The following is a description of a gene set: species: Mus musculus Mouse Gene Set: GOBP_PEPTIDYL_SERINE_AUTOPHOSPHORYLATION The phosphorylation by a protein of one or more of its own serine amino acid residues, or a serine residue on an identical protein., and this is the list of marker genes: Pikfyve (NCBI Gene Id 71407), Prkca, Mark3, Atm, Ripk1, Map2k2, Ern1, Pink1